The following is a description of a gene set: Cytokines mediate cell-cell communication in the immune system and represent important therapeutic targets. A myriad of studies have highlighted their central role in immune function, yet we lack a global view of the cellular responses of each immune cell type to each cytokine. To address this gap, the authors created the Immune Dictionary, a compendium of single-cell transcriptomic profiles of more than 17 immune cell types in response to each of 86 cytokines (>1,400 cytokine-cell type combinations) in mouse lymph nodes in vivo. A cytokine-centric view of the dictionary revealed that most cytokines induce highly cell-type-specific responses. For example, the inflammatory cytokine interleukin-1β induces distinct gene programmes in almost every cell type. A cell-type-centric view of the dictionary identified more than 66 cytokine-driven cellular polarization states across immune cell types, including previously uncharacterized states such as an interleukin-18-induced polyfunctional natural killer cell state. Mouse Gene Set: CUI_MONOCYTE_GM_CSF_RESPONSE_DN studied in species Mus musculus from publication Cui A, Huang T, Li S, Ma A, Pérez JL, Sander C, Keskin DB, Wu CJ, Fraenkel E, Hacohen N (PMID 38057668) Genes negatively differentially expressed in cell type: Monocyte upon treatment with cytokine: GM-CSF in mouse lymph nodes in vivo., and this is the list of marker genes: Zbp1 (Z-DNA binding protein 1), H2-K1, Higd2a, H2-D1, Eif3f, AB124611, Gngt2, Tmem176a, Plac8, Npc2, Cx3cr1, Arhgef18, Tnfrsf1b, Rras, Eif3h (eukaryotic translation initiation factor 3, subunit H), Itm2b, Cox7a2l, Calhm6, Eef1b2, Msrb1, Stat3, Cdkn2d, Lst1, Gpx1, Tpd52, Lsp1, Hacd4, Hpse, Smpdl3a, Lyz2, Hspa1a, Metrnl, Fau, Ifitm3, Eef2, Ifitm6, Klra2, Cybb, Abi3, Ifitm2, Cd47, Coro1a, Hspa1b, Rsrp1, Sat1, Adgre4 (NCBI Gene Id 52614), Gcnt2, Mpeg1, Apoe, Uqcrh, Tmem176b, Klf2, Serinc3, Samhd1, Pou2f2, Ms4a6b, Tnfaip8l2, H3f3a, Ms4a6c, Cd52